The following is a description of a gene set: Mouse Gene Set: GOBP_RIGHTING_REFLEX A reflex process in which an animal immediately tries to turn over after being placed in a supine position. species: Mus musculus, and this is the list of marker genes: Auts2, Pcdh15, Glra1, Glrb (NCBI Gene Id 99751), Shank1, Aldh1a3, Afg3l2, Foxp2, Npsr1, Usp46, Slc1a1, Cdh23